The following is a description of a gene set: mRNA Editing: C to U Conversion species: Homo sapiens Human Gene Set: REACTOME_MRNA_EDITING_C_TO_U_CONVERSION, and this is the list of marker genes: APOBEC2, APOBEC3B, APOBEC3H, APOBEC1, A1CF, APOBEC3C, APOBEC3A (apolipoprotein B mRNA editing enzyme catalytic subunit 3A), APOBEC4